Given this list of marker genes ATP7A, WNT7A, RTL1, SLC29A3, SCN9A, NF1, SETBP1, PCNT, CHEK2, GABRA1, EXT1, LMBR1, LONP1, FLNB, GDF5, GORAB, INTU, DYNC2H1, RB1, POR, SCN1A, LRP5, DMP1, CYP2R1, SLC35A2, EN1, ALG12, HCN1, HYLS1, PCYT1A, SEMA3E, CCN2, TBXAS1, PCDH19, SLC26A2, PRR12, COL10A1, SOX9, ADGRV1, FGFR3, CLCN5, TGFB1, FLNA, BMPR1B, P3H1, PHEX, GABRG2 (NCBI Gene Id 2566), FIBP, TTI1, RMRP, SERPINH1, COL9A3, PRRT2, TCTN3 (tectonic family member 3), SHH, ENPP1, CYP27A1, LMX1B, PDGFRB, RBM8A, SCN2A, AIFM1, CLTCL1, COL11A1, COL1A2, SLC34A3, ZSWIM6, COL11A2, TRAPPC2, GLI3, SCN1B, MEG3, SHOX, NEK1, EIF4A3, LIFR, CHST3, HPGD, COL2A1, BHLHA9, SMOC1 (NCBI Gene Id 64093), CPLANE1, DYM, GPC6, DLK1, TAF4, VDR, EXT2, CEP120 (NCBI Gene Id 153241), PITX1, ACTB, COL9A2, MMP13, SATB2, COL1A1, CYP27B1, DONSON, TP53, FGF13, IHH, CILK1, FN1, DDX6, CHD7, GABRD, LAMA5, SLC31A1, STX1B, here is a description of the gene set: species: Homo sapiens Human Gene Set: HP_ABNORMAL_TIBIA_MORPHOLOGY Abnormality of the tibia (shinbone). Abnormal tibia morphology